Given this list of marker genes PRKDC, RPL38, ABT1, C1QBP, XRCC5, SBDS, DDX3X (NCBI Gene Id 730543), EFL1, EIF6, here is a description of the gene set: species: Homo sapiens The aggregation, arrangement and bonding together of the large and small ribosomal subunits into a functional cytosolic ribosome. Distinct stages of this process take place first in the nucleolus, then in the nucleus and finally in the cytosol. Human Gene Set: GOBP_CYTOSOLIC_RIBOSOME_ASSEMBLY